The following is a description of a gene set: Mouse Gene Set: GOBP_LUNG_ASSOCIATED_MESENCHYME_DEVELOPMENT The biological process whose specific outcome is the progression of a lung-associated mesenchyme from an initial condition to its mature state. This process begins with the formation of lung-associated mesenchyme and ends with the mature structure. Lung-associated mesenchyme is the tissue made up of loosely connected mesenchymal cells in the lung. studied in species Mus musculus, and this is the list of marker genes: Fgfr2 (NCBI Gene Id 20946), Dppa2, Hoxa5, Fgf9, Ptk7, Wnt11, Shh, Fgfr1 (fibroblast growth factor receptor 1), Ctnnb1, Dppa4, Wnt7b